The following is a description of a gene set: Human Gene Set: LOPEZ_MESOTHELIOMA_SURVIVAL_OVERALL_UP from publication López-Ríos F, Chuai S, Flores R, Shimizu S, Ohno T, Wakahara K, Illei PB, Hussain S, Krug L, Zakowski MF, Rusch V, Olshen AB, Ladanyi M (PMID 16540645) Top genes associated with favorable overall survival of mesothelioma patients after surgery. Most gene expression profiling studies of mesothelioma have been based on relatively small sample numbers, limiting their statistical power. We did Affymetrix U133A microarray analysis on 99 pleural mesotheliomas, in which multivariate analysis showed advanced-stage, sarcomatous histology and P16/CDKN2A homozygous deletion to be significant independent adverse prognostic factors. Comparison of the expression profiles of epithelioid versus sarcomatous mesotheliomas identified many genes significantly overexpressed among the former, including previously unrecognized ones, such as uroplakins and kallikrein 11, both confirmed by immunohistochemistry. Examination of the gene expression correlates of survival showed that more aggressive mesotheliomas expressed higher levels of Aurora kinases A and B and functionally related genes involved in mitosis and cell cycle control. Independent confirmation of the negative effect of Aurora kinase B was obtained by immunohistochemistry in a separate patient cohort. A role for Aurora kinases in the aggressive behavior of mesotheliomas is of potential clinical interest because of the recent development of small-molecule inhibitors. We then used our data to develop microarray-based predictors of 1 year survival; these achieved a maximal accuracy of 68% in cross-validation. However, this was inferior to prognostic prediction based on standard clinicopathologic variables and P16/CDNK2A status (accuracy, 73%), and adding the microarray model to the latter did not improve overall accuracy. Finally, we evaluated three recently published microarray-based outcome prediction models, but their accuracies ranged from 63% to 67%, consistently lower than reported. Gene expression profiling of mesotheliomas is an important discovery tool, but its power in clinical prognostication has been overestimated. studied in species Homo sapiens, and this is the list of marker genes: CFI (complement factor I), ADH1B, HP, ST6GAL1, IL6R, N4BP2L1 (NEDD4 binding protein 2 like 1), FAM117A, TMT1A